The following is a description of a gene set: The process in which a Schwann cell membrane closes around an axon in the peripheral nervous system. This can be a myelinating or a non-myelinating neuron-glial interaction. Human Gene Set: GOBP_PERIPHERAL_NERVOUS_SYSTEM_AXON_ENSHEATHMENT studied in species Homo sapiens, and this is the list of marker genes: SKI, DICER1, PLEC, MYOC, NDRG1, NTRK2, CNTNAP1, ITGB4, LGI4, ILK, SIRT2, POU3F2, SLC25A46 (solute carrier family 25 member 46), COL6A1, AKT2, NF1, SH3TC2 (SH3 domain and tetratricopeptide repeats 2), NCMAP, PPP3R1 (protein phosphatase 3 regulatory subunit B, alpha), AKT1, PARD3, ARHGEF10, POU3F1 (NCBI Gene Id 5453), ADGRG6, SOD1, PRX, DAG1 (NCBI Gene Id 1605), FA2H, PALS1, NTRK3